The following is a description of a gene set: Human Gene Set: HP_ABNORMAL_CORPUS_STRIATUM_MORPHOLOGY species: Homo sapiens Abnormal corpus striatum morphology Abnormality of the striatum, which is the largest nucleus of the basal ganglia, comprising the caudate, putamen and ventral striatum, including the nucleus accumbens., and this is the list of marker genes: CP, RNASEH2B, POLR3A, NUP62, JPH3, PDE10A, TUBB3, TIMM8A, MECR, FTL, GCDH, OPHN1, NUP54, MT-ATP6, IFIH1, ADAR, VPS13A, SAMHD1, RNASEH2A, RNU7-1, TUBB2B, ASNS, BSCL2, NEK1, ATP13A2, PDE8B, LONP1, COASY, PNPT1, RANBP2, NDUFAF5, LSM11, NDE1, TREM2, TREX1, HTT, DCX, RNASEH2C, TYROBP, ATXN3, FOXP2, AIFM1, SLC2A3